The following is a description of a gene set: Human Gene Set: GOCC_NUCLEOTIDE_ACTIVATED_PROTEIN_KINASE_COMPLEX A protein complex that possesses nucleotide-dependent protein kinase activity. The nucleotide can be AMP (in S. pombe and human) or ADP (in S. cerevisiae). species: Homo sapiens, and this is the list of marker genes: PRKAA2, PRKAG1, PRKAA1, PRKAG3, SESN2, PRKAG2, PRKACA, PRKAB2 (protein kinase AMP-activated non-catalytic subunit beta 2), PRKAR2A (protein kinase cAMP-dependent type II regulatory subunit alpha), PRKAB1, PRKAR1A